The following is a description of a gene set: Genes predicted to be targets of miRBase v22 microRNA hsa-miR-218-1-3p in miRDB v6.0 with MirTarget v4 prediction scores > 80 (high confidence targets). Human Gene Set: MIR218_1_3P species: Homo sapiens from publication Chen Y, Wang X (PMID 31504780), and this is the list of marker genes: KCTD6, GRAMD2A, DYNC1LI2, LDLRAP1, HOMEZ, LSM14B (LSM family member 14B), CXXC5, DOCK7, ITM2C, PFKFB3, CRIM1, SLC38A2, MID1IP1, KBTBD3, PANK3, TBK1, HSPB8, CDK13, ATF3, JADE1, TNRC18, ANKH, ZNF544, PARP16 (poly(ADP-ribose) polymerase family member 16), ARAP3, MINDY2, IRS2, MFAP3L, CLINT1, PRH2, TP53INP2, RAB3C, HK1, GALP, APOL6, BICD2, CD8B, SLC24A2, METTL9, ZKSCAN1, CNOT6L, UBE2E2, C7 (NCBI Gene Id 636878), MANBA, ATP8B2, HOXA11, RPAIN, MRTFB, SAXO1, SLC12A5, AHNAK2, BTG2 (NCBI Gene Id 7832), KCNMA1, SPRYD7, CLN5, MYH11, NLGN1, GSTO2, HIBADH, LIMK1, NRBF2, UEVLD, INHBB, NOTCH2, BID, SMARCC1, NCOR2, SLC12A2, SRC, PWWP3B, STIM1 (stromal interaction molecule 1), LCP1, SIGLEC6, ODF2L, ZNF704, FOXP1, LMAN2L, RAC1 (Rac family small GTPase 1), TRAM1 (NCBI Gene Id 23471), ZNF507, ALG13, MYO10, SEC14L5, CDH8, DTNA, POU2F1, FNIP1, KHK, TSGA10, SPATA6